The following is a description of a gene set: from publication Lee MS, Hanspers K, Barker CS, Korn AP, McCune JM (PMID 15210650) species: Homo sapiens Human Gene Set: GSE1460_DP_THYMOCYTE_VS_NAIVE_CD4_TCELL_CORD_BLOOD_DN Genes down-regulated in comparison of CD4 CD8 thymocytes versus naive CD4 T cells from cord blood. Subpopulations of human fetal thymocyte and circulating naïve T cells were obtained through FACS sorting, including CD3-CD4+CD8- intrathymic T progenitor cells (ITTP), CD3intCD4+CD8+ \double positive\ thymocytes (DP), CD3highCD4+CD8- \single positive\ thymocytes (SP4), CD3+CD4+CD8-CD45RA+CD62L+ naive T cells from cord blood (CB4+), and CD3+CD4+CD8-CD45RA+CD62L+ naive T cells from adult blood (AB4+)., and this is the list of marker genes: FUCA1, LITAF, CRYGC, LPCAT3 (lysophosphatidylcholine acyltransferase 3), PCLO, EFEMP2, KCNV1, NCK2, LORICRIN (loricrin cornified envelope precursor protein), RPS27, C9orf78, ATP6V1B1, DCSTAMP, MORC4, TP63, CD34 (CD34 molecule), TPM2, DNAH17, PHF1, KRT2, HLA-DQA1, PCYOX1L, AGTR1, BIN2, IGHV5-78, TNFSF13, JCHAIN, CNN1, RACK1, SLC24A1, RAB11FIP3, CYTIP, MTUS1, ASAH1, KIF17, APOD, NKX6-1 (NCBI Gene Id 4825), TAP2, PDE4B, IMPDH1, TBC1D29P, KLK10, TRPC6, MEOX2, EDAR (ectodysplasin A receptor), RPL27, NSFL1C, PPP1R3D, FBXO46, RPL8, SCML1, RAMP3, IL1RAPL2, TFF2, PPP2R3A, HCP5, C8A, B4GALT1, ACP5, DGKZ, IL19, ABCA4, COX7A2, AMPH, MORC2, PCOLCE2, DDX60, APBA2, ACKR2, S1PR1, IL11RA, KLHDC3, RPS18, GVINP1, PITX3, HLA-DMA, RPGRIP1, HLA-F, SLC2A11, OPRPN, RNF39, CPZ, BTN2A1, NUDT2, DSCAM, STK10, ZC3H7B, PIP4K2B, ACTN1, AGAP2, KCNK3, KCNJ8, SLC31A2, SLC17A6, PF4V1 (NCBI Gene Id 5197), TRIP10, GPR162, MINDY1, ATP8A1, ERAP1, R3HDM4, DLX5, PCMTD2, SLCO3A1, TFF1, WFDC8, DOLK, CASQ1, PSORS1C2, CRTAP, NR2E1, BST2 (bone marrow stromal cell antigen 2), DZANK1 (double zinc ribbon and ankyrin repeat domains 1), ZNF750, FGD1, STX16, EHD2, FAU, TBCC, MEGF6, CARTPT, NPY4R, NOX3, TAPBP, SEPTIN9, PRRC2B, HS1BP3 (HCLS1 binding protein 3), EIF3D, ERAL1 (Era like 12S mitochondrial rRNA chaperone 1), SIK3, SIK2, LTK (NCBI Gene Id 4058), IFITM2, RPS6KA3, PXN, TUBAL3, FAP, SEMA4D, RPS6KA5, CLUAP1, ZMYND8, SLC17A1, TMEM156, EGFL6, TIMP1, MYBPC2, WNT6, RFX2, SLC6A16, GCAT, HMOX1 (heme oxygenase 1), GAD2, DLGAP1, AHCYL2, HTR1F (NCBI Gene Id 3355), CYLD, CDH12, BTN2A2 (butyrophilin subfamily 2 member A2), BABAM2, GNA12, RPS17P5, KCNC3, ABCC3, HPR, SERINC5, PLSCR3, RIMBP2, RPL23AP32, EEF1D, PHF20, GPR182, BLTP1, SFI1, ASAP3 (ArfGAP with SH3 domain, ankyrin repeat and PH domain 3), TLR3, ETHE1, NACC2, MYOZ3, ALS2CL, EMP1, GYS2, BIN1, NKAPD1, EFNA2, GABRE, ITGA8, RSAD1, STAT1, RHOF, NFKB1, IFT140, RAB20, LAMC1, GRB10, DRD2, INPP4B, KTN1, PCDHB1, CCDC69